The following is a description of a gene set: Human Gene Set: HP_FRONTALIS_MUSCLE_WEAKNESS Frontalis muscle weakness studied in species Homo sapiens Reduced strength of the frontalis muscle (which is located on the forehead)., and this is the list of marker genes: MYO9A, SLC5A7, VAMP1, COL13A1, SLC25A1, SYT2, CHAT, AGRN, SNAP25, SLC18A3